The following is a description of a gene set: studied in species Mus musculus part of: Signaling by FGFR2 This event has been computationally inferred from an event that has been demonstrated in another species.<p>The inference is based on the homology mapping from PANTHER. Briefly, reactions for which all involved PhysicalEntities (in input, output and catalyst) have a mapped orthologue/paralogue (for complexes at least 75% of components must have a mapping) are inferred to the other species. Reactome Pathway: Negative regulation of FGFR2 signaling electronically inferred by orthology from the curated human pathway, and this is the list of marker genes: Fgf2, Grb2, Fgf5, Fgf17, Mapk3, Fgf4, Fgf7, Fgf22, Fgf6, Cbl, Fgf10, Ubb, Fgf1, Fgf16, Fgf8, Fgf20, Rps27a, Frs2, Spry2 (sprouty RTK signaling antagonist 2), Fgf23